Given this list of marker genes LRRN3, NAA16, PPTC7, IQSEC1, ARRDC5, SNORD4A, RAI1, TUT4, ALDOB, EP300, GTPBP3, AGAP4, LINC01089, NPIPB15, FCGBP, CD248, CSAD, NPIPA1, PDE7A, SREBF1, AAK1, NSUN5P1, here is a description of the gene set: To elucidate gene expression pathways underlying age-associated impairment in influenza vaccine response, we screened young (age 21-30) and older (age >= 65) adults receiving influenza vaccine in two consecutive seasons and identified those with strong or absent response to vaccine, including a subset of older adults meeting criteria for frailty. PBMCs obtained prior to vaccination (Day 0) and at day 2 or 4, day 7 and day 28 post-vaccine were subjected to gene expression microarray analysis. We defined a response signature and also detected induction of a type I interferon response at day 2 and a plasma cell signature at day 7 post-vaccine in young responders. The response signature was dysregulated in older adults, with the plasma cell signature induced at day 2, and was never induced in frail subjects (who were all non-responders). We also identified a mitochondrial signature in young vaccine responders containing genes mediating mitochondrial biogenesis and oxidative phosphorylation that was consistent in two different vaccine seasons and verified by analyses of mitochondrial content and protein expression. These results represent the first genome-wide transcriptional profiling analysis of age-associated dynamics following influenza vaccination, and implicate changes in mitochondrial biogenesis and function as a critical factor in human vaccine responsiveness. Human Gene Set: THAKAR_PBMC_INACTIVATED_INFLUENZA_AGE_21_30YO_VS_70PLS_0DY_UP from publication Thakar J, Mohanty S, West AP, Joshi SR, Ueda I, Wilson J, Meng H, Blevins TP, Tsang S, Trentalange M, Siconolfi B, Park K, Gill TM, Belshe RB, Kaech SM, Shadel GS, Kleinstein SH, Shaw AC (PMID 25596819) Genes up-regulated in peripheral blood mononuclear cell young adults vs seniors in young adults (21-30), seniors (70+) after exposure to Inactivated influenza vaccine, time point 0D studied in species Homo sapiens